Given this list of marker genes NOG, B3GALT6, DYNC2LI1, HOXA13, SALL4, NXN, MYH3, LRP4 (LDL receptor related protein 4), HOXD13, PRKACA, ESCO2, FGFR2, RECQL4, APC, MAP3K7, COL27A1, PITX1, FLNB, CHSY1, BPNT2, SMOC1, EVC2, MACROH2A1, RBM8A, ATP7A, GLI1, FGFR3, EVC, BHLHA9, PAX3, ROR2, SHH, POR, BMPR1B, FBLN1, LMBR1, PRKACB, GDF5, FLNA, here is a description of the gene set: studied in species Homo sapiens Human Gene Set: HP_CARPAL_SYNOSTOSIS Synostosis (bony fusion) involving one or more bones of the carpus (scaphoid, lunate, triquetrum, trapezium, trapezoid, capitate, hamate, pisiform). Carpal synostosis